Given this list of marker genes KCNIP3, KIF3C, CERS6 (ceramide synthase 6), TBC1D9, SEMA3F, SCARF2, DST, PLCH2, EPDR1, ITGA5, HSPB8, TRIM29, ASPH, CUX1, here is a description of the gene set: Genes consistently down-regulated in mammary luminal progenitor cells both in mouse and human species. from publication Lim E, Wu D, Pal B, Bouras T, Asselin-Labat ML, Vaillant F, Yagita H, Lindeman GJ, Smyth GK, Visvader JE (PMID 20346151) INTRODUCTION: Molecular characterization of the normal epithelial cell types that reside in the mammary gland is an important step toward understanding pathways that regulate self-renewal, lineage commitment, and differentiation along the hierarchy. Here we determined the gene expression signatures of four distinct subpopulations isolated from the mouse mammary gland. The epithelial cell signatures were used to interrogate mouse models of mammary tumorigenesis and to compare with their normal human counterpart subsets to identify conserved genes and networks.METHODS: RNA was prepared from freshly sorted mouse mammary cell subpopulations (mammary stem cell (MaSC)-enriched, committed luminal progenitor, mature luminal and stromal cell) and used for gene expression profiling analysis on the Illumina platform. Gene signatures were derived and compared with those previously reported for the analogous normal human mammary cell subpopulations. The mouse and human epithelial subset signatures were then subjected to Ingenuity Pathway Analysis (IPA) to identify conserved pathways.RESULTS: The four mouse mammary cell subpopulations exhibited distinct gene signatures. Comparison of these signatures with the molecular profiles of different mouse models of mammary tumorigenesis revealed that tumors arising in MMTV-Wnt-1 and p53-/- mice were enriched for MaSC-subset genes, whereas the gene profiles of MMTV-Neu and MMTV-PyMT tumors were most concordant with the luminal progenitor cell signature. Comparison of the mouse mammary epithelial cell signatures with their human counterparts revealed substantial conservation of genes, whereas IPA highlighted a number of conserved pathways in the three epithelial subsets.CONCLUSIONS: The conservation of genes and pathways across species further validates the use of the mouse as a model to study mammary gland development and highlights pathways that are likely to govern cell-fate decisions and differentiation. It is noteworthy that many of the conserved genes in the MaSC population have been considered as epithelial-mesenchymal transition (EMT) signature genes. Therefore, the expression of these genes in tumor cells may reflect basal epithelial cell characteristics and not necessarily cells that have undergone an EMT. Comparative analyses of normal mouse epithelial subsets with murine tumor models have implicated distinct cell types in contributing to tumorigenesis in the different models. species: Mus musculus Human Gene Set: LIM_MAMMARY_LUMINAL_PROGENITOR_DN